The following is a description of a gene set: This event has been computationally inferred from an event that has been demonstrated in another species.<p>The inference is based on the homology mapping from PANTHER. Briefly, reactions for which all involved PhysicalEntities (in input, output and catalyst) have a mapped orthologue/paralogue (for complexes at least 75% of components must have a mapping) are inferred to the other species. electronically inferred by orthology from the curated human pathway Reactome Pathway: Synthesis of UDP-N-acetyl-glucosamine species: Mus musculus part of: Synthesis of substrates in N-glycan biosythesis, and this is the list of marker genes: Gfpt2, Nagk, Amdhd2, Gnpnat1, Renbp